Given this list of marker genes SF3B5 (splicing factor 3b subunit 5), CST5, TRIM62, TNFSF14, FAM163A, TNIP3, ABCA11P, LINC01120, PXDNL, PHYHIPL, PLAAT1, SUSD4, SLC22A12, PLCB4, RCAN1, EDEM1, NOS3, WDR49, HSD3B1, CRNN, NDUFB7, ELAVL2, RNF182, TNFAIP2, CITED1, AVP, GRPR, SBSPON, HELQ, HSP90AB1, CYP2A6, CALHM2, RRH (NCBI Gene Id 10692), ZNF473, NR2C2AP, RPS27, KHDRBS3, NHLRC2, FAM186B, PKDCC, SRSF4, SNRPB (small nuclear ribonucleoprotein polypeptides B and B1), POLD2, TNN, CISH (cytokine inducible SH2 containing protein), RAB25, PTGS2, GANAB, CCN1, NEK9, FOXN3-AS2, PRSS8, GAL3ST3, DYNLRB2, MEI1 (meiotic double-stranded break formation protein 1), USP2, NMUR2 (neuromedin U receptor 2), ATP5MG, RDH16, PCBD1, P2RX2, DSCAM-AS1, C10orf53, LTB, RARS1, LINC00667, SERHL2, EPAS1, SCAMP2 (secretory carrier membrane protein 2), C5, SHANK1, SLC16A3, GAS8-AS1, RGS12, GUCA1C (guanylate cyclase activator 1C), MRPL37, JPT2, LINC00474, KYAT1, TBC1D5, TSR1, AKT2, AZIN2, WFDC5, FLOT1, CHEK2, SLC7A8, CD83, ST6GALNAC4, CHRNA3, EDA2R (ectodysplasin A2 receptor), SLC8A2, SPMIP6, OR10A5, FCRL3, TRIM68, ZNF460, HLA-DOB, ACTN2, ZNF473CR, OR2S2, ITPR1, OPN5, RHOXF1, PGAM1, TOP3B, CNDP1, GLYAT, RAB11FIP5, AREG, ASGR2, STARD7-AS1, LCIIAR, EGR3, LINC00930, MYBPC2, CDC37, CRABP2, DHX34, PISD, CLEC18A, ZNF426, BHLHE40, CCDC54, GJA4, MDK, GBP6, CPE, SV2B, OASL, ADGRB3, CSTA, CD160, PIP5K1A, CCL5, LPAR1, SLC35B1, SIAH2-AS1, SPRR1A, DDOST, TOP3A, UNC119, ATP5MF, AMIGO3, CXCL2, MGAT5, TIMM8B, SLC7A5, M1AP, ZNF257, TTC7B, EHD4, TEX26-AS1, LYPLA2, SLC20A2, MRLN, TGFBI, TRAF4, ALDH18A1, GPR83, MALL, LRFN5, ZDHHC3, CARINH, GLRA3, LINC00161, LINC03007, VMA21, MEP1A, IPO13, LMAN1L, MMP24, IFIT2, PLA2G2D, CSNK2B, TAS2R19, MED16, FAM193A, FST, ALKBH5, TUBB4A, LINC00668 (long intergenic non-protein coding RNA 668), JMJD6, CLCF1, DAOA, CHST3, FLT3, ENSG00000288891, YRDC, FSD2, GPR143, SLC22A11, NYAP2, here is a description of the gene set: Human Gene Set: GSE26488_WT_VS_HDAC7_KO_DOUBLE_POSITIVE_THYMOCYTE_DN Genes down-regulated in double positive thymocytes: wildtype versus HDAC7 knockout. species: Homo sapiens from publication Kasler HG, Young BD, Mottet D, Lim HW, Collins AM, Olson EN, Verdin E (PMID 21398603) Abstract of publicaton: CD4/CD8 double-positive (DP) thymocytes express the transcriptional repressor Histone Deacetylase 7 (HDAC7), a class IIa HDAC that is exported from the cell nucleus after T cell receptor (TCR) engagement. Through signal-dependent nuclear export, class IIa HDACs such as HDAC7 mediate signal-dependent changes in gene expression that are important to developmental fate decisions in multiple tissues. We report that HDAC7 is exported from the cell nucleus during positive selection in thymocytes, and regulates genes mediating the coupling between TCR engagement and downstream events that determine cell survival. Thymocytes lacking HDAC7 are inefficiently positively selected due to a severely shortened lifespan and exhibit a truncated repertoire of TCR Jalpha segments. The expression of multiple important mediators and modulators of the response to TCR engagement is altered in HDAC7-deficient thymocytes, resulting in increased tonic MAP kinase activity that contributes to the observed loss of viability. Remarkably, the activity of Protein Kinase D, the kinase that mediates nuclear export of HDAC7 in response to TCR signaling, is also increased in HDAC7-deficient thymocytes, suggesting that HDAC7 nuclear export governs a self-sustaining auto-excitatory loop. These experiments add to the understanding of the life/death decision in thymic T cell development, define a novel function for class IIa HDACs, and point to a novel feed-forward mechanism whereby these molecules regulate their own state and mediate stable developmental transitions. Title of manuscript: Nuclear Export of Histone Deacetylase 7 During Thymic Selection Mediates Immune Self-tolerance. abstract of manuscript: Histone Deacetylase 7 (HDAC7) is a TCR signal-dependent regulator of differentiation that is highly expressed in CD4/CD8 double-positive (DP) thymocytes. Here we examine the effect of blocking TCR-dependent nuclear export of HDAC7 during thymic selection, through expression of a signal-resistant mutant of HDAC7 (HDAC7-delta-P) in thymocytes. We find that HDAC7-delta-P Transgenic thymocytes exhibit a profound block in negative thymic selection, but can still undergo positive selection, resulting in the escape of autoreactive T cells into the periphery. Gene expression profiling reveals a comprehensive suppression of the negative selection-associated gene expression program in DP thymocytes, associated with a defect in the activation of MAP kinase pathways by TCR signals. The consequence of this block in vivo is a lethal autoimmune syndrome involving the exocrine pancreas and other abdominal organs. These experiments establish a novel molecular model of autoimmunity and cast new light on the relationship between thymic selection and immune self-tolerance. Goal of Microarray experiment: We did these experiments to determine how alteration of the function of HDAC7, a site-specific and signal-dependent repressor of transcription, changes gene expression in CD4/CD8 DP thymocytes.